The following is a description of a gene set: Human Gene Set: HP_ROUND_FACE The facial appearance is more circular than usual as viewed from the front. Round face species: Homo sapiens, and this is the list of marker genes: P3H1, RNU4ATAC (NCBI Gene Id 57788), PIGY, PGAP3, IARS1, PIGV, ALMS1, NEDD4L, CACNA1C, SLC10A7, ITGA3, FBN1, PEX1, TRAPPC9, DNMT3A, CANT1, KDM4B, PDE11A, GJA5, CENPE, SLC37A4, PPP1R15B, PRKAR1A, HRAS, HDAC4, GJA8, TAFAZZIN, PIGA, GNAI3, UBAP2L, ACTG2 (NCBI Gene Id 72), PLCB4, PAM16, LTBP3, ECEL1, PEX2, PEX6, ADAMTSL2, SEPTIN9, KAT5, SUZ12, AFF4, SEMA5A, EED, KMT2A, TRMT10A, AGO1, GNAS, PGAP2, PIGW, MED13L, KDM6B, CRTAP, XYLT1, AKT1, FGD1, KIF15, EZH2, LMNA, TMEM67, LMX1B, STX16, B3GLCT, TECPR2, CPE, SPECC1L, COL11A2, EXOC8, IFT56 (intraflagellar transport 56), BRPF1, TOR1A, BBS2, MAPK8IP3, PHIP, WWOX, ZBTB18 (zinc finger and BTB domain containing 18), ANKRD11, PDE4D, CTNND2, RECQL, SH3BP2, EIF2S3, CSGALNACT1, MRPS28, SMC1A, PRKAR1B, COL2A1, DIS3L2, FIBP, CHSY1, NRAS, FBXO31, COL6A1, NEXMIF, PIGL, PIGO (NCBI Gene Id 84720), STXBP1, COL11A1, MRPL12, NSD1, HOXD13, ADARB1 (NCBI Gene Id 104), RBL2, ZBTB24, HNRNPC, ARMC5